The following is a description of a gene set: Reactome Pathway: Maturation of TCA enzymes and regulation of TCA cycle species: Homo sapiens part of: Citric acid cycle (TCA cycle) (Citrate-synthase)-lysyl-methyltransferase (CSKMT, METTL12) transfers three methyl groups from S-adenosylmethionine (SAM) to lysine-395 of citrate synthase (CS). The expression of CSKMT is low or absent in many normal organ tissues, but the trimethylated form is predominant in most cell lines tested. The modification is evolutionarily conserved, with contradicting reports on the activity of modified CS, while the effect on the whole CS/ACO2 metabolon was not investigated. Oxalocetate inhibits methyltransferase activity., and this is the list of marker genes: SDHD, CS, LYRM4, CSKMT, ISCA2, ACAT1, SDHAF3, ACO2, ISCA1, SDHAF2, SIRT3, SDHAF1, IDH2, SDHB (succinate dehydrogenase complex iron sulfur subunit B), ISCU, FXN, SDHC, SDHA, SDHAF4, NFS1